Given this list of marker genes FAS, CFLAR, CASP10, FADD, FAF1, CASP8, here is a description of the gene set: studied in species Homo sapiens Human Gene Set: GOCC_CD95_DEATH_INDUCING_SIGNALING_COMPLEX A protein complex formed upon binding of Fas/CD95/APO-1 to its ligand. The complex includes FADD/Mort1, procaspase-8/10 and c-FLIP in addition to the ligand-bound receptor.